The following is a description of a gene set: Human Gene Set: MIR4748 species: Homo sapiens from publication Chen Y, Wang X (PMID 31504780) Genes predicted to be targets of miRBase v22 microRNA hsa-miR-4748 in miRDB v6.0 with MirTarget v4 prediction scores > 80 (high confidence targets)., and this is the list of marker genes: SLC46A1, LIPA, YWHAE, WDHD1, UTY, ELOVL5, ZNF479, NSD2, SSH2, ZNF765, GABRG2, ZC2HC1A, SRSF2, IRAK1BP1, TCP11L2, ATMIN, EML1, RAB27B, CHN2 (NCBI Gene Id 644086), NR2F2, TP63, SLC39A4, KIAA1217, TANK, SPZ1, SOCS5, FBXO28, TMEM106B, DNAJA3, ESYT3, TBCA, FNDC3A, TSPAN13, ZNF28, ZNF462, PSME3IP1 (proteasome activator subunit 3 interacting protein 1), ZNF117, STAG2, PPP2R5A, ZNF483 (NCBI Gene Id 158399), NOP58, UBE2G2, FUBP3, GREM1, ZNF493 (zinc finger protein 493), SLITRK4, SYT16, HNRNPUL2, GM2A, EYA1, KCNJ13, ADAM17, SRSF11, OPRM1, CKAP2L, PCYOX1, POU4F1, DDX3Y, ZNF140 (NCBI Gene Id 7699), PCDHB4, DDX3X, IMPACT, SLA, KCNH8, ZNF107, HHEX, NAA15, RCAN2, MARCHF7